Given this list of marker genes SH3BP1, EXOC3, EXOC5, EXOC3L2, MYRIP, EXOC8, EXOC7 (exocyst complex component 7), WASHC1, EXOC6B, EXOC3L4, TNFAIP2, RAB10, EXOC3L1, EXOC2, EXOC4, EXOC6, EXOC1, here is a description of the gene set: species: Homo sapiens A protein complex peripherally associated with the plasma membrane that determines where vesicles dock and fuse. At least eight complex components are conserved between yeast and mammals. Human Gene Set: GOCC_EXOCYST